The following is a description of a gene set: Down-regulated in HEK293 cells (kidney epithelium) by treatment with sodium arsenite. Chronic, low-level exposure to arsenic frequently results in skin, lung, bladder, and kidney cancer. Since arsenic is primarily excreted via the kidney, this study focused on this target tissue. Gene array was used as a sensitive low-level monitor of the impact of arsenic on this target tissue. Arsenite was chosen as the chemical species of arsenic since As(III) species are touted as the cellular toxic form of arsenic. Human embryonic kidney cell line HEK293 cells were incubated with 1, 10, and 25 microM arsenite for 6 or 24 h. Total RNA from treated and control cells was isolated, reverse transcribed, and labeled with Cy3 or Cy5, and hybridized to a human cDNA microarray. Hybridizations were performed four times using independent total RNA preparations to ensure reproducibility. Raw data from 10 and 25 microM treated cells exposed for 6 h was normalized within, and between, hybridizations followed by identification of genes affected by arsenite exposure based on practical significance (2-fold change up or down) and reproducibility (affected in four of six measurements). In these studies, genes (HMOX1, MT1E, or FOSL1, etc.) were up-regulated, and genes (MYC, JAK1, or CENPE, etc.) were down-regulated. Genes identified at 10 and 25 microM arsenic exposure were then examined after 1 microM treatment for 6 or 24 h. Expression of affected genes showed a dose-dependent (1-25 microM) trend that was apparently not time-dependent (6 vs. 24 h). The affected genes indicate that even this realistic, low-level arsenite exposure was recognized by the HEK293 cells (e.g. metallothionein genes) and produced an oxidative stress (e.g. heme oxygenase gene). These affected genes were characterized as stress response genes, proto-oncogene, signaling molecules, transcription factors, chemokine receptors, proteolytic enzymes, ESTs, and unknown genes. These findings imply that arsenite induces complex cellular injury and the cellular adaptation to As(III) is associated with alterations in the expression of many genes. Human Gene Set: ZHENG_RESPONSE_TO_ARSENITE_DN studied in species Homo sapiens from publication Zheng XH, Watts GS, Vaught S, Gandolfi AJ (PMID 12679051), and this is the list of marker genes: MYC, ADAMTS1, JAK1, MMP13, PHLDB2, SERPINB9P1, IL1A, PTPN11, CENPE, SLC44A2, INSIG1, TPR